Given this list of marker genes NAA38, UCN, MMP14, PGAP4, RRN3, TTC1, RALGDS, PCDHAC1, MT3, ATL3, POFUT2, OPN3, ACTN2, LSM7, NAE1, NIBAN1, PDZK1IP1, LHX2, LRRC59, TXNL1, EPHB2, SLC35G6, VAMP2, ZDHHC5, SLURP1, SAMSN1, ETS2, TP53RK, EIF3D, WDR43, CACNA1F, RANBP3, USP47, MRTO4, PHOX2B, CHCHD4, CHD1, MKKS, PDE6D, TRMT112, HDAC1 (NCBI Gene Id 3065), KCNN4, CHST7, FLT4, WDR36, CD200, PELI1, SLFN12L, HAT1, FAM50B, ALDH7A1, NOTCH3, CNN3 (calponin 3), BMAL2 (NCBI Gene Id 56938), MSN, NME6, BCL7C, NDEL1, MEMO1, EGLN2, MTMR7, GNB1, DENR, METAP1, HAO2, ITGB1, RASA2, SERPINB11, STRN3, FLT1, TNFRSF1B (TNF receptor superfamily member 1B), TRPC4AP, CPD, AFG2A, THRSP, CLK3, USO1, RGL1, UBE2O, ATXN7L1, FOXB1, PSMD6, DUSP2, DDA1, SLC41A2, USP10, ASB12, BHLHA15, PPP1R37, CD47, MDM1, HHATL, BCL2L1, TMEFF1, RPP40, SLC31A1, APOA2, WBP2, YRDC, SLC28A2, AFM, GPR88, HINFP, DCAKD, UBAC2, THOC1, ESD, HDHD2, BLOC1S6 (NCBI Gene Id 26258), FAM184B, GBE1, MBD2, IFNAR2, IPO4 (NCBI Gene Id 79711), CORIN, IFIH1, SEC13, FARP2, TJAP1, BNIP2, BATF, FRMD6, TSPAN33, OAS2, TSC22D1, BIRC3, HNRNPH3, RND3, MOB4, PMM2, TMEM47, ATF3, KHDC4, VDAC3, PDCL3, CD81, HARS1, ACTN1, KRI1, DNAJB13, LIN9, FTCD, RCAN2, NR3C1, UBXN8, SHC1, BMPR2, IRGM, ATP6V1E1, HS3ST3A1, OSTC, CWH43, DNM3, AKNA, CHIC2, PLSCR1, KATNBL1, NIPSNAP3A, ME1, MDFIC, PIK3CG, PPP1R15A, NAA35, MORC3, RAB10, VSX1, CCNL1, DNAJB5, CREBBP, TOP1, TRA2B, RAP2A, FBXW11, DNM1L (NCBI Gene Id 692222), MAFF, PTGES, COL4A2, IGF2BP1, POP7, ZNF436 (NCBI Gene Id 80818), TAF1C, POLR2C, NCBP1, OCSTAMP, RNF6, YARS1, CCT7, KLHDC8A, REXO4, CTTN, BRD8, SNX10, ACIN1, RAI14 (retinoic acid induced 14), IER3, ARHGAP21, CYFIP2, FRK, ARG2, here is a description of the gene set: species: Homo sapiens Human Gene Set: GSE17721_CTRL_VS_GARDIQUIMOD_6H_BMDC_DN from publication Amit I, Garber M, Chevrier N, Leite AP, Donner Y, Eisenhaure T, Guttman M, Grenier JK, Li W, Zuk O, Schubert LA, Birditt B, Shay T, Goren A, Zhang X, Smith Z, Deering R, McDonald RC, Cabili M, Bernstein BE, Rinn JL, Meissner A, Root DE, Hacohen N, Regev A (PMID 19729616) mouse primary BMDCs were stimulated with tlr ligands and gene expression changes were profiled on Affymetrix arrays Genes down-regulated in comparison of control dendritic cells (DC) at 6 h versus those stimulated with Gardiquimod (TLR7 agonist) at 6 h.